The following is a description of a gene set: Cardiovascular calcification Abnormal calcification in the cardiovascular system. Human Gene Set: HP_CARDIOVASCULAR_CALCIFICATION studied in species Homo sapiens, and this is the list of marker genes: LMNA, SAMHD1, PDGFB, LDLRAP1, GATA5, NKX2-5, ERCC8, FBN1, RNASEH2A, RIGI, ADAR, B2M, GBA1, SMAD6, PCSK9 (proprotein convertase subtilisin/kexin type 9), HGD, APOB, SLC20A2, SLC34A2, LDLR, MTX2, ABCG8 (NCBI Gene Id 64241), LSM11, ZMPSTE24, RNASEH2B, ABCG5, PDGFRB, STAT1, NOTCH1, RNASEH2C, GALNT3, TREX1, RNU7-1, ERCC6, ABCC6, ENPP1, IFIH1, NT5E